Given this list of marker genes SYT4, PLCB1, DAGLA, CNR1, GUCY1A1, FABP5 (fatty acid binding protein 5), FARP1, TENM2, ABHD6 (NCBI Gene Id 96026), DAG1, here is a description of the gene set: Human Gene Set: GOBP_RETROGRADE_TRANS_SYNAPTIC_SIGNALING Cell-cell signaling from post to pre-synapse, across the synaptic cleft. species: Homo sapiens